Given this list of marker genes Chka, Chat, Bche, Slc5a7, Flvcr2, Ache, Acp3, here is a description of the gene set: Mouse Gene Set: GOMF_CHOLINE_BINDING Binding to choline, the amine 2-hydroxy-N,N,N-trimethylethanaminium. species: Mus musculus